Given this list of marker genes Smc1b, Smc3, Rad21l, Rad21, Stag3, Rec8, Smc1a, here is a description of the gene set: A cohesin complex that mediates sister chromatid cohesion during meiosis; has a subunit composition distinct from that of the mitotic cohesin complex. species: Mus musculus Mouse Gene Set: GOCC_MEIOTIC_COHESIN_COMPLEX